The following is a description of a gene set: Homologous DNA Pairing and Strand Exchange Mouse Gene Set: REACTOME_HOMOLOGOUS_DNA_PAIRING_AND_STRAND_EXCHANGE studied in species Mus musculus, and this is the list of marker genes: Rad50, Mre11a, Rbbp8, Atm, Rad51c, Kat5, Chek1, Wrn, Rad51b, Nbn, Brip1, Rmi2, Rad51ap1, Dna2, Rmi1, Xrcc2, Top3a, Exo1, Bard1, Blm, Brca2, Rad51d, Rad51, Palb2, Xrcc3, Brca1